The following is a description of a gene set: studied in species Mus musculus Mouse Gene Set: GOBP_CARDIAC_VASCULAR_SMOOTH_MUSCLE_CELL_DIFFERENTIATION The process in which a relatively unspecialized cell acquires specialized features of a cardiac vascular smooth muscle cell. A cardiac vascular smooth muscle cell covers the heart vasculature and lacks transverse striations in its constituent fibers., and this is the list of marker genes: Myocd, Gper1 (G protein-coupled estrogen receptor 1), Prok2, Pbrm1, Smad6, Mir143, Pdgfb, Vangl2, Ctnnb1, Notch1, Mesp1, Gata6, Pdgfrb, Hey2, Vegfa, Mir145a, Srf